The following is a description of a gene set: species: Homo sapiens Human Gene Set: GOBP_EPITHELIAL_STRUCTURE_MAINTENANCE A tissue homeostatic process required for the maintenance of epithelial structure., and this is the list of marker genes: TFF1, LDB2, MIR204 (NCBI Gene Id 406987), LSR, PKP3, TLR4 (toll like receptor 4), SLC22A5, VSIG1, CRACD, MUC2, STRAP, SOX9, TLR9, IL17A, IL10RA, NR1I2, PBLD, INAVA, CXADR, MUC13, CROCC, LACRT (lacritin), TFF2, LDB1, NEUROD1, SRF, NOD2, TFF3, PIWIL4 (piwi like RNA-mediated gene silencing 4), ZNF830, PRRC1, MUC4, RBP4, ILDR1, SERPINA3, MKS1, HTR4, MUC6, SCRIB